The following is a description of a gene set: Mouse Gene Set: GOCC_CILIARY_PLASM species: Mus musculus All of the contents of a cilium, excluding the plasma membrane surrounding the cilium., and this is the list of marker genes: Rpgrip1l, Dnah3, Lca5l, Saxo2, Nme7, Sptbn5, Cfap276 (cilia and flagella associated protein 276), Dync1i2, Akap14, Bbs7, Spag16, Dynlt4, Lca5, Cep162, Cenpf, Saxo4, Cfap100, Dnah12, Bbs5, Cfap119, Rsph1, Nme5, Cfap107, Bbof1, Ift70a1, Tekt1, Ak8, Dnah11, Nme8, Odad2, Ift70a2, Dync2i2, Ccdc66, Dnali1, Dzip1l, Septin7, Rp1l1, Gas8, Kif17, Spmip9, Rsph9, Kif19a, Cfap44, Rsph14, Mapt (microtubule-associated protein tau), Cfap91, Drc1, Dnhd1, Prkaca, Gli2, Bbs1, Gli1, Ribc1, Ttll10 (tubulin tyrosine ligase-like family, member 10), Rsph4a, Tekt5 (NCBI Gene Id 70426), Dusp21, Camsap3, Cfap36, Arl13b, Gli3, Dcdc2a, Cfap20, Pierce2, Ttll8, Ribc2, Cfap70, Spag6, Ttll3, Tektl1, Clxn, Brwd1, Nek4, Dync2h1, Dnah5, Tubb4b, Dusp3, Dnah7b, Cfap69, Cfap144, Ift140, Cfap206 (cilia and flagella associated protein 206), Cfap53, Spmip8 (NCBI Gene Id 73407), Ssna1, Dnai1, Togaram1, Dync2li1, Cfap95, Dnah17, Mns1, Pacrg, Pierce1, Cfap73, Atg14, Dnai4 (NCBI Gene Id 242584), Spag8, Arl3, Cimip2c (ciliary microtubule inner protein 2C), Rsph3b, Pttg1, Dynlt2b, Dnah8, Dnajb13, Dydc1, Ccdc113, Efcab6, Efhc2, Cfap74, Efhc1, Efhb, Traf3ip1, Dnah2, Dnaaf1, Wdpcp, Ift88, Ccdc96, Cfap77, Rsph3a, Dnah1, Spata4, Inpp5e, Tubb4a, Ambra1, Septin2, Dnai7, Tuba1a, Saxo1, Drc3, Rp1, Arl6, Ccdc40, Rsph6a, Tmem67, Kif3a, Cimip2b, Cfap90, Cfap210, Cimip2a, Ropn1l, Tekt4, Cfap43, Ctsh, Cfap141, Spef1, Spef1l, Dnah9, Gnat3, Hydin, Ccdc39, Cfap68, Dnah7a, Rpgrip1, Spmip10, Ift57, Tulp3, Wdr11, Cfap52, Wdr35, Dnah6, Pik3r4, Odad1, Cfap45, Cfap161, Spmip5, Spmip6, Cfap126, Prkar1a, Cys1 (cystin 1), Enkur, Mak, Ccdc103, Ccdc63, Septin9, Odad3, Map1lc3b, Spag6l, Arfgef2, Dnal1, Dnah10, Cfap61, Iqub, Ccsap, Cfap221, Atg7, Lrrc51, Ift70b, Tssk6, Ift172, Prkar2a, Odad4, Cfap54, Tekt2, Spaca9, Ccdc65, Tekt3, Atg5 (NCBI Gene Id 97669), Dnah7c, Atg16l1, Spmip11, Kifap3, Dnai2, Tektip1, Spata7 (NCBI Gene Id 319842, spermatogenesis associated 7), Dnai3, Gabarap, Spag17 (NCBI Gene Id 74362)